The following is a description of a gene set: Abnormal elasticity of skin Any abnormal increase or reduction in skin elasticity. species: Homo sapiens Human Gene Set: HP_ABNORMAL_ELASTICITY_OF_SKIN, and this is the list of marker genes: DKC1 (dyskerin pseudouridine synthase 1), WDR19, CD96, HPGD, KCNH1, VAC14, CEP55, KIAA0586, INSR, IARS1, VPS37D, NR3C1, ABL1, PRMT7, SPINT2 (serine peptidase inhibitor, Kunitz type 2), GGCX, EHMT1, EZH2, FGFR3, TBL2, GTF2IRD2, TRIP4, USP8, WRN (WRN RecQ like helicase), MRPS22, IFT43, IPO8, TWIST2, MEGF8, POLD1, ALG8, ENPP1, RIN2, USP48, BRAF, TBL1XR1 (TBL1X/Y related 1), BGN, XYLT2, SMAD2, PARN, TP53, SON, COG7, H1-4, SKI, ANTXR1, SMARCAD1, ATP6V1B2, NEPRO, TINF2, TMEM270, MRPS16, RAF1, RFC2, COL1A1, RAD21, ALOXE3, KRAS, CHST3, COPB1, DLK1, ATP6AP2, KIF22, TNXB, B4GALT1, ALG12, CHD8, PIGA, TERT, LTBP4, TGM5, NIPAL4 (NIPA like domain containing 4), ARMC5, WLS, MAPRE2, PAX2, FKBP14 (FKBP prolyl isomerase 14), MAP2K1, ADAMTSL2, EDA, ZNF469, LTBP1 (NCBI Gene Id 4052), NSD1, GPX4, DLG4, NAA10, FGF20, SUZ12, COL1A2, ZMPSTE24, PIK3R1, PUF60, FOXC1 (forkhead box C1), COL5A1, CHST14, MAN2B1, DSE, ALDH18A1, TGFB3, LMNA, METTL27, PTDSS1, MGP, PITX2, GSN, ALOX12B, PDE11A, SMARCD2, MLXIPL, TGFBR2, KCNN3, FGFR2 (fibroblast growth factor receptor 2), GORAB, FIG4, STX1A, COL12A1, CYP4F22, PRDM5, XYLT1, FBN1 (NCBI Gene Id 7470), TRPS1, PLOD1, GNB2, FBLN5, FBXO11, EXT1, ATRX, LOX, RTEL1, GNAS, COL3A1, CSTA, SLC25A24, NPR2, PIGQ, MAP3K7, NBAS, THBS2, SMARCA2, BUD23, C1R (complement C1r), SLC7A7, C1S, LIPN, PAH, KDM1A, FKBP6, PTPN11, SH3PXD2B, ATP6V0A2, AHDC1 (AT-hook DNA binding motif containing 1), MAN1B1, TGFB2, RTL1, CFTR, SRD5A3, B3GAT3, LSS, ATP7A, TGM1, RIT1, SLC39A13, PYCR1, CDH23, BCL11B (NCBI Gene Id 64919), MEG3, AIP, B3GALT6, PDGFRB, SLC2A10, INPPL1, HRAS, OTUD5, FLNA (filamin A), LIMK1, CSPP1, TRAF7, PEX1, ABCC6, SLC26A2, ABCA12, MICU1, NDUFB11, EFEMP2, SPARC (NCBI Gene Id 6678), CUL4B, SMAD3 (NCBI Gene Id 51521, SMAD family member 3), WDR37, TUBB, TGFBR1, EIF4H, SHOC2, H4C5, CDK13, AKT3, TBX15, AARS1, WDR35, SPEN, AEBP1, WDR81, NCF1, ACD, ATP6V1E1, LZTR1, GBA1, NDUFB10, ATP6AP1, MRAS, ATP6V1A, CTNNB1, KMT2C, FGD1, MAP2K2, GTF2IRD1, RPS6KA3, COL5A2, GTF2I, YY1 (YY1 transcription factor), SDR9C7, EBP, B4GALT7, PTEN, PRKAR1A, ZNRF3, CDKN2A, ASPRV1, MTAP, ADAMTS2, BAZ1B, IFT140, SLC6A8, EFEMP1, SULT2B1, DNAJC30, ASXL1, ELN, SEPTIN9, CLIP2